Given this list of marker genes SIGLEC9, NAT8L, FIGN, MYT1L, PLA2G4D, NFIA, SART3, CDK15, CALN1, SLC35A3, SKIDA1, FOXK2, SP100, ZRANB1, ZNF37A, TEC, ZKSCAN7, ATXN7, SLC19A4P, RBFOX1, CACNA1I, USP13, WBP1L, SOX14, CMPK2, BCL11A, GCNT2, ZBTB20, ZDHHC17, PDAP1, TBC1D3H, GLS2, TREML2 (NCBI Gene Id 79865), SMAD4, LRTM2, HTR7, TACC1, DSCAML1, VAV3, NLGN3, ABHD10, ZNF484, DPY19L3, NCBP2, LRRC58, AKAP6, DOCK3, GAD2, APLF, ADGRL1, TLCD2, R3HDM2, LAYN, BDP1 (NCBI Gene Id 59278), TRIQK, THUMPD2, CREB3L3, XKR4, OLR1, SLC5A7, UHRF2, ZNF641, MYOCD, KLK7, TBC1D3, LMX1A, NSD1, PTBP2, PFN4, CUTC (NCBI Gene Id 51076), ARK2N, C2orf72, N4BP2, MBNL1, PEX5L, ILRUN, ZFAND1, PPFIA2, DENND1B, UBE2Z, TNFAIP8L1, FAM131A, RASA2, ADGRF5, LRRIQ3, IGF2BP3, TAB2, SMARCE1, CDC42BPA, NFYA, HPX, SPPL3, here is a description of the gene set: studied in species Homo sapiens from publication Chen Y, Wang X (PMID 31504780) Human Gene Set: MIR6888_3P Genes predicted to be targets of miRBase v22 microRNA hsa-miR-6888-3p in miRDB v6.0 with MirTarget v4 prediction scores > 80 (high confidence targets).